Given this list of marker genes PARK7, MUC2, SUMF1, ATP13A2, PRNP, here is a description of the gene set: Human Gene Set: GOMF_CUPRIC_ION_BINDING Binding to a cupric ion, copper(2+). studied in species Homo sapiens